The following is a description of a gene set: Human Gene Set: GSE17974_IL4_AND_ANTI_IL12_VS_UNTREATED_24H_ACT_CD4_TCELL_DN from publication Elo LL, Järvenpää H, Tuomela S, Raghav S, Ahlfors H, Laurila K, Gupta B, Lund RJ, Tahvanainen J, Hawkins RD, Oresic M, Lähdesmäki H, Rasool O, Rao KV, Aittokallio T, Lahesmaa R (PMID 20620947) The aim of this dataset was to study in detail the transcription kinetics initiated by cytokine IL-4 in early differentiation of Th2 cells. Genes down-regulated in comparison of CD4 T cells treated with IL4 and anti-IL12 at 24 h versus the untreated cells at 24 h. species: Homo sapiens, and this is the list of marker genes: CMTM5, PLA2R1, CYP4A22, GPR155, LACC1, KHDC1L, HERC6 (NCBI Gene Id 55008), BCL2L14, XAF1, LGALS9, SLC27A2 (NCBI Gene Id 8523), SLAMF6, IL12RB2, CYP4Z2P, INTU, OR51E1, STAP1, DBIL5P, LIF, TBX21, KNOP1, IQGAP2, IFIH1, ZP2, COL6A3, CPNE5, SOX7, TRPC6, OASL, DHX58, CXCL5, SH3RF3-AS1 (NCBI Gene Id 100293319), STX3, BST2, ISG15, FAM43A, MX1, WWTR1, FGF9, ZBED2, CABP5, ATF3, IFIT1, MMP10, GBP5, CD300LD-AS1, SLC8A1-AS1, TDRD7 (tudor domain containing 7), SMARCA1, CFAP92, PALLD, H3C12, LYST, OSM, IFI27, PGM2L1, TOX2, ISG20, PATE2, ITIH4, FCER1G, ANXA3, SBSPON, LINC01242, USP18, OAS1, ZSCAN26, PKHD1, CXCL3 (C-X-C motif chemokine ligand 3), TRIM38, HFE, TRAK1, DNAJC28, MARCHF3, ORAI3, HERC5, KRT36, CCDC28A-AS1 (CCDC28A antisense RNA 1), TRPC1, PMFBP1, CCDC168, IFIT2, BCL10-AS1, CCL4, TYMP, LINC00115, EIF3J-DT, USP5, DZANK1, PRTFDC1, GTF2IP20, NRBP2, KAT7, FCGBP, MT1E, RHOU, ITCH, SLAMF7, FTCDNL1, SNX7, VAV2, TNFSF10, TPH2, GAL, NUTM2A-AS1, OSGIN2, IGFBP4, ADGRE1, LINC02604, VWA5A, GIMAP1, C3orf52, OR3A1, CFLAR-AS1, LAMP3, ANXA2P2, PLCZ1, LRIT1, CASK, ZNF831, GAL3ST4, SGK2, RGL4, GRIK1, GIMAP4, LHX6, LINC00964, LOXL4, TMEM154, SP100, LINC01465, SIX3, HSD11B1, OAS2, CXCL10, TNFSF13B, PLSCR1, TMCC1, ARHGEF39, ARMC2, EPSTI1, ANKDD1A, MORN3, BEND6, IMMP2L, TBX22, IFI6, INSRR, BCL7A, TMEM140, IFI44, TMEM132D, CSMD2, FHIT, BBIP1, CXCR3, MUC1, CMAHP, ATAD5, KLHDC7B (NCBI Gene Id 113730), PDE4B, MYO3B, APELA, ENC1, OR2F2, SAMD9L, SP140, GCSAM, CCDC141 (coiled-coil domain containing 141), ZNF691, ODF2L, ZFP37, OVOL1, FZD5, TNFAIP8L2, ERICH6, MX2, IFIT3, GZMB, HSH2D, ANXA2, TNFRSF14-AS1, CCL20, IFI44L, FETUB, INSM2, SWSAP1, SERPINC1, CASP4LP, RPL34-DT, CALR3, ARHGAP15, SH3BP4 (NCBI Gene Id 23677), HPYR1